The following is a description of a gene set: Weakness of the muscles of the pelvic girdle (also known as the hip girdle), that is, lack of strength of the muscles around the pelvis. Pelvic girdle muscle weakness Human Gene Set: HP_PELVIC_GIRDLE_MUSCLE_WEAKNESS species: Homo sapiens, and this is the list of marker genes: COL13A1, DYSF, RYR1, DPM3, AGRN, DNA2, GNE, MUSK, LRP4, HNRNPDL, AK9, FLNC, PHKA1, ACTA1, MT-TE, MYOT, TNNT1, HACD1, TTN, SCN4A, GYG1, CHRNE, RAPSN, TNPO3, CHRND, TPM2, TPM3, SMN1, FKRP, DGUOK, PNPLA2, SELENON, MYH7, SMCHD1, VCP, TRIM32, ITGA7, MYL2, SMN2, DNAJB6, DOK7 (NCBI Gene Id 619409), COL6A3, CHRNA1, CHRNB1, PHKB (NCBI Gene Id 5257), CRYAB, ANO5, PLEC, MAP3K20, SGCB